The following is a description of a gene set: Senescence-Associated Secretory Phenotype (SASP) studied in species Mus musculus Mouse Gene Set: REACTOME_SENESCENCE_ASSOCIATED_SECRETORY_PHENOTYPE_SASP, and this is the list of marker genes: Anapc5, Anapc15, Cdkn1a, Cdkn1b, Cdkn2b, Cdc16, Rps6ka2 (ribosomal protein S6 kinase, polypeptide 2), Rps27a, Cdk6, Ubc, Uba52rt, Ubb, Mapk7, Ube2s, Rps6ka3, Cdc27, Fzr1, Cebpb, Uba52, Cdk2, Cdc26, Ube2e1, Ube2d1, Anapc7, Ehmt2, Mapk3, Anapc11, Rps6ka1, Anapc4, Cdk4, Ccna1, Ccna2, Anapc2, Anapc10, Mapk1, Ube2c, Cdc23, Ehmt1 (euchromatic histone methyltransferase 1), Anapc1, Cdkn1c, Anapc16